The following is a description of a gene set: Genes up-regulated in macrophages with knockout of HDAC3: untreated versus LPS. Human Gene Set: GSE33162_UNTREATED_VS_4H_LPS_STIM_HDAC3_KO_MACROPHAGE_UP from publication Chen X, Barozzi I, Termanini A, Prosperini E, Recchiuti A, Dalli J, Mietton F, Matteoli G, Hiebert S, Natoli G (PMID 22802645) species: Homo sapiens Pan-Hdac inhibitors (HDACi) are endowed with a potent anti-inflammatory activity, but the relative role of each of the eleven Hdac proteins sensitive to HDACi to the inflammatory gene expression program is unknown. Using an integrated genomic approach we found that Hdac3-deficient macrophages are unable to activate almost half of the inflammatory gene expression program when stimulated with lipopolysaccharide (LPS). A large part of the activation defect is due to loss of basal and LPS-inducible expression of IFNb, which in basal cells maintains Stat1 protein levels, and after stimulation acts in an autocrine/paracrine manner to promote a secondary wave of Stat1-dependent gene expression. We show that loss of Hdac3-mediated repression of nuclear receptors leads to hyperacetylation of thousands of genomic sites and associated gene derepression. The upregulation of the constitutively expressed prostaglandin endoperoxide synthase, Ptgs1 (Cox-1), has a causative role in the phenotype, since its chemical inhibition reverts the Ifnb activation defect. These data may have relevance for the use of selective Hdac inhibitors as anti-inflammatory agents., and this is the list of marker genes: GIMAP7, EFHD2, ANXA4, SH2D1A, ECH1, GGH, E2F8, TMEM208, RFC2, SMS (spermine synthase), ZCCHC18, MXD3, CTNNA1, UGDH, NFE2, NUDT19, CD68, MRPL57, NUP37, DDX19A, CENPA, PLAC8, ALCAM, CXCL10, AP1S2, CBX1, GNB1, CRIP2, MCM6, CDC25B, ITGAM (NCBI Gene Id 3684), CDK4, YWHAE, CD82, SSRP1, ACADL, TALDO1, GARS1, MIS18BP1, TMBIM4, ENTPD1, RNH1, DAPK2 (NCBI Gene Id 23604), PTPMT1, CMC2, DNMT1, PPP1CA, CAT, ORC6 (origin recognition complex subunit 6), AK3, YWHAH, CAPN2 (calpain 2), CSNK2B, MRPL27 (mitochondrial ribosomal protein L27), PPP2R3C, PSMC5, PSMB10, CISD1, POLD2, INCENP, GPC1, NCALD, TOMM6, NDUFB3, CPTP, MRPL4, ITGB1, SDF2L1, ADPRH (ADP-ribosylarginine hydrolase), MCM2, LITAF, MYADM, SNRPA, SSR2 (NCBI Gene Id 6746), TYROBP, CYFIP1, LIG1, TXN, NDUFB6, WDHD1, SYCE2, IAH1 (isoamyl acetate hydrolyzing esterase 1 (putative)), COX6C, UBE2C, GBP7, NDUFA9, PRIM1, STIL, GNB2, TPX2, PTMS, FLAD1, TBX21, NRP1, MRPL10, ARPC5, DSTN, SNRNP25, CRELD2, TRPS1, PRF1, IFITM2, NAXE, TBCB, S100A13, ITPA, MAPK6, PLK1, CDK2, H2AX, IFNG, MYL9, BLMH, ATP5ME, TFDP1, PIH1D1, MTHFS, MID1IP1, TRAM1, ASF1B, THTPA, FAM110A, SLC25A11, PTPN12, SH3BGRL3, CROT (NCBI Gene Id 54677), P2RY12, TPI1 (NCBI Gene Id 7167), UQCRC2, TMPO, LYL1, TIPIN, MANF, PKIG, DEGS1, PIGF, ATP5PF, TMEM97, ANXA1, COX5A, DOCK5, ITGAX, DPAGT1 (NCBI Gene Id 1799), TMEM163 (NCBI Gene Id 81615), CRIP1, MRPL18 (NCBI Gene Id 96273), MCM7, CRYBG3, CHMP5, SURF1, NCAPD2, HPN, CTSD, ATP6V1A, GATM, GNA15, POLR3C, LXN, ARPC4, XPNPEP1, BCL11A, TTK, MVB12A, PPIH, SUMO3, ABRACL, EMC2, CDKN2C, GRN, REEP5 (NCBI Gene Id 94845), CDKN2AIPNL, C6orf89, TMEM14C, MT1E, UNC119B, KIF20A, HTRA2, NUP93, SPI1, BSCL2 (NCBI Gene Id 84753), PGK1, MT2A, OTULIN, ALDH9A1, GNG2, CDK1, HMGB1 (high mobility group box 1), VAMP3, SEPTIN11, AURKB, GPSM2, MTCH1, CDC20, FKBP1A, ATXN7L1, RTCA, AIDA, EPHA1, GNPDA1, RAB11A